The following is a description of a gene set: Signaling. species: Homo sapiens Human Gene Set: MODULE_176, and this is the list of marker genes: CHGA, C1R, UGT2B10, TCF15, COL5A2, PLXNB1, ISL1, DPYSL3, GATM, WASF3, CHI3L2, NEO1, NPTX1, PCP4, AGXT, CTSK, JAK3 (Janus kinase 3), DPEP1, TFPI2, ALOX15, GJB1, SCTR, THBS2, SFN, PTPRO, NTRK3, P2RX1, CDH2, TGFA, TRIM29, SCG2, S100A5, IGF1, TNFRSF11B, GAP43, MAOB, CYP2J2, POU2F2, FCGR3A, GABRB3, C5, PRKCQ, TCP10L3, KLHDC3, DPP6 (NCBI Gene Id 653748), SPARCL1, EPHB1 (EPH receptor B1), CCL4, CRMP1, EFNA5, WT1-AS, HRK, PAH, ST6GAL1, PDK4 (pyruvate dehydrogenase kinase 4), SRPX, ETV3, ADRB2, ANK3, KYNU, CHGB, CX3CR1 (NCBI Gene Id 2836), KIAA0040, IL3, COL3A1, NFKBIL1, GLRA2, SERPINA6, GRIK1, BAAT, GRK5, FUT7, GBP1, CYP2B6, IGF2, FPR1, MMP3, SOX9, CSH2, ACSM3, QPCT, TGM3, EPAS1, RREB1, NAT2, CYP2A7, TSPAN8, CXCL3, CRHR2, AADAC, CP (NCBI Gene Id 1356, ceruloplasmin), UGT1A6, SPRR1B, RBMY1A1, DHRS2, MEOX1, CAV1, PTPRG, EDA, PTPRS, SIM2, COL15A1, GSTM5, FHL2, SLC28A1, CPS1, TNNT3, LGALS4, UGT2B7, NOVA1, RND3, GPX3, EYA2, CLDN10 (NCBI Gene Id 9071), CDKN1C, CCL20 (NCBI Gene Id 6364), CD163, AQP4 (NCBI Gene Id 50660), RBP4, RXRG (retinoid X receptor gamma), KIR2DL4, CCL17, MFAP5, KCNB1, GPC3, TCN2, SERPING1, ACR, ROR1, C1S (complement C1s), MYBPC1 (NCBI Gene Id 9116), KRT13, UGT8, TNP1, DPP4, TF, ZNF143, CASR, ALDH3A2, NNAT, PPP3CA, NMU, PSG6 (NCBI Gene Id 5675), DVL1, GAD1, ITGA3, COX7A1, RAPGEF1, OLFM1 (NCBI Gene Id 22825), LRRC32, OMG, CYP2D6, AZGP1, GATA2, RGN, TNC, AMELY, ARSB, KRT4, DEFB1, GRP, ALDH1A3, NEUROD1, GAS1, WFDC2, ASGR2, BRME1, CEACAM1, MYH2, ITIH3, DDC, SELENOP, PTH1R, LY6D, FABP4, ERCC8, LUM, KRTAP5-9, NPY, NRG1, SCN4A, S1PR1, CYP1B1, ADH1B, MEF2C (NCBI Gene Id 4208), A2M, KRT86, CDH17, ADCYAP1R1, NPY1R, SYT1, RGS7, RCAN2, KCNJ15, SDS, MYOG, TYRP1, CSF2RB, GATA1, TIMP4, NTSR1, CETP, ANGPT1, S100P (S100 calcium binding protein P), HPGD, TYR, APLP1, PTPRR, PMEL (premelanosome protein), UMOD, PAX5 (paired box 5), ITIH2, RPS6KA2, F3, CXCL2, PTPRD, SLC34A1, NELL1, CBLN1, CYP3A7, LAMA3, GSTM3, NOS1, SMTN, TMSB15A, KLRC1, MLC1, APOH, EHHADH, C7